The following is a description of a gene set: species: Mus musculus Mouse Gene Set: TABULA_MURIS_SENIS_AORTA_PROFESSIONAL_ANTIGEN_PRESENTING_CELL_AGEING from publication Tabula Muris Consortium (PMID 32669714), and this is the list of marker genes: Ms4a6c, Cyba, Ins2, Ifitm3, Calr, Rpl7, Rpl8, H2-DMa, B2m, Nfkbia, Lpxn, Psap (NCBI Gene Id 19156), Gsn, Tmsb10, Eef1a1, Alox5ap, Trf, Rpsa, Pcbp1, Pfn1, Lilrb4a (leukocyte immunoglobulin-like receptor, subfamily B, member 4A), Mgp, Clic1, Papss2, Wfdc17, Cfl1, Rps5, Rps7, Anxa2, Rpl18, Rpl13, Srgn (serglycin), Reep5, Sdc4, Cpne1, Phf11b, Dld, Adgre5, Fcer1g (NCBI Gene Id 98395), Cd52, Lyz2, Calm1, Rpl10, Snx2, H2-Aa, Hsd17b8, Fos, Dusp1, Cdk2ap2, Krt15, Ccrl2, Rpl28, Psma7, Malat1, Plac8, Ms4a4c, Oas1a, H3f3b, Rsrp1, Ly6a, Coro1a (NCBI Gene Id 16902, coronin, actin binding protein 1A), Itm2b, Tyrobp, H2-Ab1, Rplp0, Sh3bgrl3, Atg3, Tgif1, Sparc, Ly6e, Psmb8, Actb, Pilrb1 (NCBI Gene Id 170741), Arpc2, H2-DMb1, Ifi30, Dcn, Fxyd5, Krt14, Arpc1b, Rpl13a, Cd74, Rps16, Rps14 (NCBI Gene Id 99773), Syngr2, Arhgdia, Rpl36 (NCBI Gene Id 54217), Ctsz, Rpl7a (NCBI Gene Id 30787), Rps3, Shisa5, Apoe, Timp3, H2-K1, Btg2, Tgfbi, Ctss, H2-D1, Junb, Ly6c2, Grn, Actl6a, Lum, Rpl4, Ctsc, Cebpb, Cdkn1a, Gm2a, H2-Eb1, Cd68, Ccl4, Rps20, Tmsb4x, Npm1, Rpl3, Arhgdib, Eif5a, Capg, Rps19, Ifitm2 (interferon induced transmembrane protein 2), Tspo, Rack1, Ccl2, Cox4i1, Rps10